The following is a description of a gene set: Conjunctival icterus is a condition where there is yellowing of the whites of the eyes. This is most commonly seen in patients who have liver disease. Conjunctival icterus Human Gene Set: HP_CONJUNCTIVAL_ICTERUS studied in species Homo sapiens, and this is the list of marker genes: FH, PIGA, SLCO1B1, PIEZO1, UBR1, PKHD1, SLCO1B3